Given this list of marker genes Fdps, Stard4, Ces1b, Igf2, Dab2, Cga, Ces1h, Scp2, Ces1d, Igf1, Prkaca (protein kinase, cAMP dependent, catalytic, alpha), Abcg4, Mapk1, Sec14l2, Nr1d1, Paqr3, Star, Srebf1, Qki, Abcg1, Gh, Mbtps2, Gnai1 (G protein subunit alpha i1), Ifng, Bmp6, Ces1c, Npy1r, Fshb (follicle stimulating hormone beta), Fgf1, Ces1e (NCBI Gene Id 13897), Ces1f, Apoa1, Adora2b, Srebf2, Apoe, Cyp7a1, Ces1a, Igf1r, Tnf, Scap (SREBF chaperone), Il1a, Ppargc1a (NCBI Gene Id 320239), Nr5a2, Wnt4, Cyp17a1, Ces1g, Por, here is a description of the gene set: Mouse Gene Set: GOBP_POSITIVE_REGULATION_OF_STEROID_METABOLIC_PROCESS species: Mus musculus Any process that activates or increases the frequency, rate or extent of the chemical reactions and pathways involving steroids.